The following is a description of a gene set: species: Homo sapiens from publication Ramirez K, Chandler KJ, Spaulding C, Zandi S, Sigvardsson M, Graves BJ, Kee BL (PMID 22608498) Expression profiling of Rag2-deficient Ets1++ and Rag2-deficient Ets1-- mature NK cells and WT bone marrow progenitors, WT T cells, and WT Pro B cells Human Gene Set: GSE37301_LYMPHOID_PRIMED_MPP_VS_RAG2_KO_NK_CELL_DN Genes down-regulated in lymphoid primed multipotent progenitors versus RAG2 knockout NK cells., and this is the list of marker genes: LPAR1 (NCBI Gene Id 1902), ZBED1, MAK, CDH10, TNFRSF10D, SEC14L3, GPRC5A, HOXA3, RAB30, ASH1L, VPS13D, NINJ2, OR3A3, ELF5, CREG1, LRFN4, HES1 (hes family bHLH transcription factor 1), NKX2-2, GNAT3, CYB5R4, CLCA1, CEBPE, PHC2, RPS14, ZCCHC4, GSTA3, CHGB, MUC2, PPP4R1, ZNF76, VGLL3, NRXN2 (neurexin 2), PLOD2, CUL4B, MPO, HHLA1, IL1RAPL1, NUP188, MS4A4A, GRIK5, TRA2B, NME8, YTHDF1, FAM110D, ALDH3A1, CA12, C8A, PRAMEF11, LRRC8D, RAB40AL, H3C12, HNRNPU (heterogeneous nuclear ribonucleoprotein U), KRT5, PCDH12, MYBPC1, LILRB4, PIWIL2, TXNL4A, CELP, DENND5A, MS4A2, RPL32, B2M, ENC1, PLK1, SCNN1D, PFAS (phosphoribosylformylglycinamidine synthase), MEIS1 (Meis homeobox 1), DNAI4, SNRPF, CTF1, ZNF529, PCSK5, GUCA2A, PTPRZ1, SLC47A1, ATP5PF, RAC3, LRRN2, DYNLRB1, AFDN-DT, FOXB1, ENSG00000290731, SLC9A2, MFAP1, HOMER3, FNDC3B, ANPEP, NFIB, TIE1, SALL1, PLLP, MUC3A, MRPS31, CARHSP1, MARCKSL1, TSKS (NCBI Gene Id 60385), CRYBB1, HSD17B1, SNAI1, PIGC, LCE2B, TEX15, IARS1, TBCB, SYT5, PPFIBP2, CD48, EPHB2, PSG4, ERBB4, PTPRT, LRRC19, AXL, NYNRIN, L3MBTL1, ADGRB1, ADGRA2, PCDH17, FMOD, RFXANK, LRRC42, PRSS12, LHFPL6 (LHFPL tetraspan subfamily member 6), LGALS9, EIF2AK1, IRX4, CRISP1, NDUFS2, BCOR, TBC1D31, TNS3, ACTN3, MNDA, SHPK, PYCR3, CRMP1, GPBP1L1, MAD1L1, CAMKK2, GABRB3, SPTBN2, ALOX15, GRM8, FAM124B, NALF1, MYH10, SCN1A, LGALS4, TTC28, CENPU, ZNF142, ACSL6, CSN1S1, CSF3, MSN (NCBI Gene Id 4478), SCUBE2, HLX, GPR17, CEMIP, CDC42BPA, ABCA3, DNM3, IFIT1, ULK4, CLEC11A, OGFRL1, IFNGR2, CENPA, EHBP1, LHB, ANK2, MRM1, PLPPR1, TRMO, CTAG2, CLGN, DHRS11, APOF, HINT1, EIF4A2, MAGED1, ARHGAP22, NDST4, PSMD11, PRR14L, ANKRD36BP2, MAGEA3, GAB1, TBXT, TRIP12, CFAP46, HCRTR2, AGXT, PCLO